Given this list of marker genes BMP1 (bone morphogenetic protein 1), PAM16, SETBP1, EZH2, GNPNAT1, here is a description of the gene set: Human Gene Set: HP_WIDE_DISTAL_FEMORAL_METAPHYSIS Increased width of the distal part of the shaft (metaphysis) of the femur. species: Homo sapiens Wide distal femoral metaphysis